The following is a description of a gene set: Human Gene Set: GOBP_RESPONSE_TO_LITHIUM_ION studied in species Homo sapiens Any process that results in a change in state or activity of a cell or an organism (in terms of movement, secretion, enzyme production, gene expression, etc.) as a result of a lithium (Li+) ion stimulus., and this is the list of marker genes: ADCY7, SHH, ID2 (NCBI Gene Id 3398), IMPA2, CDH1, LIG4, CALR, NFATC4, FABP4, GRIA1, SLC13A5, MYOG, CEBPA (CCAAT enhancer binding protein alpha), CDKN1B, GSK3A, XRCC4, SLC13A2